The following is a description of a gene set: Genes up-regulated in comparison of naive B cells versus day 0 monocytes. Immune cell-specific expression is one indication of the importance of a gene's role in the immune response. In order to identify such patterns, we set out to broadly profile gene expression in a variety of immune cells. species: Homo sapiens from publication Abbas AR, Baldwin D, Ma Y, Ouyang W, Gurney A, Martin F, Fong S, van Lookeren Campagne M, Godowski P, Williams PM, Chan AC, Clark HF (PMID 15789058) Human Gene Set: GSE22886_NAIVE_BCELL_VS_MONOCYTE_UP, and this is the list of marker genes: HAUS5 (HAUS augmin like complex subunit 5), SPRY4, IGHM, CLCN4, TNFSF4, CD24, TBC1D30, PKIA, ZBTB24, CD69, IGKC, TSHB, CD200, MZB1, FGF7, IFNA17, MCF2L, ENDOD1, SOBP, NIPSNAP3B, USP9Y, CD22, FZD6, SMAGP, IFNA7, PAX5, CHD7, LBH, GTPBP3 (NCBI Gene Id 84705), SP140, TTC39A, BACH2, CDCA8, ITPR3, CD40LG, SLC38A1, DBNDD1, MYOZ3, KATNBL1 (katanin regulatory subunit B1 like 1), TRAF5, COBLL1, ABCB4, MYEF2, GPR18, IDI2-AS1, STAP1, IGHD, TAF4B, TIAM2, SMPX, ABLIM1, ZNF493, SKAP1, FNBP1L, SEL1L3, DLG5, WDR33, GABRB1, HRH4, FCMR, GARRE1, CD72, IGLV1-44, POLR1HASP, SLC6A16, BLNK, SCD5, PAWR, YPEL1, BANK1, MOXD1, GINS1, SLC35F2, CHL1, TBC1D19, BCL7A, TSPAN13 (tetraspanin 13), CFAP44, NCR3, SLC24A1, PEG10 (NCBI Gene Id 651242), LARGE1, KLHL35, ZNF506, ZKSCAN7 (NCBI Gene Id 80241, zinc finger with KRAB and SCAN domains 7), CNKSR2, TRAF4, RPL23AP53, IGLL3P, GPRASP1, SLC9A7, RUBCNL, ZSCAN18, RRAS2, CHST3, AUTS2, LTB, VPREB3, ZNF529, PTPRCAP, PAIP2B, ANKRD34C, AUNIP, FAM30A, MARCHF3, RHPN1-AS1, CD19, SNAP91, TRIB2, BCL11A, CENPM, DNAI4, AP3M2, FCRL2, MS4A1, MIR600HG, GPA33, UTP25, DPPA4, LRBA, POU6F1, BACE2 (beta-secretase 2), SCN3A, GPM6A, TIMELESS, GJA9, CEP72, SNHG20, RIC3, KIAA1549L, SLC25A16 (solute carrier family 25 member 16), IL21R, PTPRK, ZFTA, FZD10, NOS1, TCL1A, FBXO4, NEIL3, NAA40, IL4R, MTCL1, GOLGA8B, RASGRP3, CD79A, IGKV1D-13, TSPYL5, GSTA1, FRAS1, POU2AF1, ISL1, C2CD3, SEMA4F, PGPEP1, ULBP1, SPIB, TMEM156, CXCR4, RFPL3, ZNF571, PIK3C2B, PDLIM1, SCLY, HLA-DOA, HYDIN, NPY4R, MAGED1, MCTP2, TPD52, DDR1, UST, NR3C2, DEFA5, OIP5, CPA3, SLC12A2, MORC4, CD79B (NCBI Gene Id 974), LRRC37A3, TFDP2, CR2, P2RX5, CORO2B, DCAF17, ZNF154, HOPX, DSP, PNOC, CEP43, CCR6, AGBL2, CNR1, HLA-DOB, FBLN1, OTUD3, IFNA16, DLEU1